The following is a description of a gene set: electronically inferred by orthology from the curated human pathway part of: SLC-mediated transport of organic anions Reactome Pathway: Organic anion transport by SLC22 transporters studied in species Mus musculus This event has been computationally inferred from an event that has been demonstrated in another species.<p>The inference is based on the homology mapping from PANTHER. Briefly, reactions for which all involved PhysicalEntities (in input, output and catalyst) have a mapped orthologue/paralogue (for complexes at least 75% of components must have a mapping) are inferred to the other species., and this is the list of marker genes: Slc22a8, Slc22a6, Slc22a12